The following is a description of a gene set: Human Gene Set: HP_ELEVATED_SERUM_ACID_PHOSPHATASE species: Homo sapiens Elevated serum acid phosphatase, and this is the list of marker genes: CA2, OCRL, CLCN7, TNFRSF11B, PSAP, LRP5